Given this list of marker genes Tmem267, Gfral, Sox2, Zswim6, Primpol, Ctnnal1, Fhip1a, Fmnl2, Rgs8, here is a description of the gene set: species: Mus musculus from publication Chen Y, Wang X (PMID 31504780) Genes predicted to be targets of miRBase v22 microRNA mmu_miR_6993_3p in miRDB v6.0 with MirTarget v4 prediction scores > 80 (high confidence targets). Mouse Gene Set: MIR_6993_3P